Given this list of marker genes IHH, PRKAR1A, GPX4, BGN, PDE4D, here is a description of the gene set: A cone-shaped appearance of the epiphyses of the metacarpal bones, producing a 'ball-in-a-socket' appearance. This epiphyses are located at the distal ends of the metacarpal bones. Cone-shaped metacarpal epiphyses species: Homo sapiens Human Gene Set: HP_CONE_SHAPED_METACARPAL_EPIPHYSES